Given this list of marker genes AMELY, BMP7, IRAK4, SIPA1L1, SEPTIN7, CHRNA2, RFX7, PDE4DIP, SLC1A3, BCO2, here is a description of the gene set: from publication McCabe CD, Spyropoulos DD, Martin D, Moreno CS (PMID 18339881) Human Gene Set: MCCABE_HOXC6_TARGETS_UP Homeobox transcription factors are developmentally regulated genes that play crucial roles in tissue patterning. Homeobox C6 (HOXC6) is overexpressed in prostate cancers and correlated with cancer progression, but the downstream targets of HOXC6 are largely unknown. We have performed genome-wide localization analysis to identify promoters bound by HOXC6 in prostate cancer cells. This analysis identified 468 reproducibly bound promoters whose associated genes are involved in functions such as cell proliferation and apoptosis. We have complemented these data with expression profiling of prostates from mice with homozygous disruption of the Hoxc6 gene to identify 31 direct regulatory target genes of HOXC6. We show that HOXC6 directly regulates expression of bone morphogenic protein 7, fibroblast growth factor receptor 2, insulin-like growth factor binding protein 3, and platelet-derived growth factor receptor alpha (PDGFRA) in prostate cells and indirectly influences the Notch and Wnt signaling pathways in vivo. We further show that inhibition of PDGFRA reduces proliferation of prostate cancer cells, and that overexpression of HOXC6 can overcome the effects of PDGFRA inhibition. HOXC6 regulates genes with both oncogenic and tumor suppressor activities as well as several genes such as CD44 that are important for prostate branching morphogenesis and metastasis to the bone microenvironment. species: Homo sapiens Genes with promoters bound by HOXC6 in LNCaP cells (prostate cancer) and up-regulated upon loss of function (LOF) of HOXC6.